Given this list of marker genes STXBP1 (syntaxin binding protein 1), D2HGDH, GCDH, TSEN54, SLC19A3, CCDC88A, ZNHIT3, TK2, here is a description of the gene set: Infantile encephalopathy studied in species Homo sapiens Human Gene Set: HP_INFANTILE_ENCEPHALOPATHY Encephalopathy with onset in the infantile period.